Given this list of marker genes APEX2, MRPL37, LHX6, FAM227B, GAA, QSOX1, NUP54, EXOC2, AP1B1, DXO, TFAP4, OR7C1, MCAT, CIC, LRRC14, FBXO10, ARL4A, FBXO41, CKAP4, PRKCSH, LMNB2, LONP2, PPM1G, ARHGEF1, CD247, SAG, DHX30, ALKBH4, ACVR1B, PYM1, CCAR1, VPS33A, FAM204A (NCBI Gene Id 63877), WDR73, AP5B1, G3BP1, RNF220, RBM38, VPS4A, GLE1, FHOD3, KXD1, ANKH, ALDH1L2, TOMM20, PLCG1, CREBBP, ASB4 (ankyrin repeat and SOCS box containing 4), GPM6A, SNHG32, KCNK6, FSCN3, PNPLA1, BEND5, WDR82, STPG1, NKRF, RAB11B, REEP1, LYAR (NCBI Gene Id 55646), GNL3, FYN, GJB1, IP6K1, NRM, SCARB1, RAD1, RASL11B, RALGPS2, EXT1, MED24, EXOSC1, REXO4, RCC1L, HSD17B14, KCTD14, LSM2, ELF3, PCDHB7, WDR33, ARMCX2, RNF103 (NCBI Gene Id 7844), LIPT2, CNOT11, TNRC6B, RAB35, MAP3K14, PPP4R3B, PKD1, GABRG2, CHURC1, ZC3H8, S100A8, NAV3, PPIG, NXPE3, REV3L (REV3 like, DNA directed polymerase zeta catalytic subunit), PLD1, ERAL1, SLIT2, EIF3G, ZDHHC12, MAPK6, SNHG7, ENOPH1, SLC23A3, RBM34, PRR9, HIVEP3, RAB36, GPATCH4, RRAS2, SH2D2A, NMNAT3, EXOSC4, NOMO1, MTUS1, MCM2, RASSF2, B3GNT8, NFYA, POLR1C, PHLDA3, FPR3, SPAG16, FUCA1, BAX, ARL13A, BDH1, LRWD1, UBE2N, NIN, SET, RPL36, RAPGEF1, MED13L, BTC, LPXN, TTC13, DDRGK1, ZNF346, HADHA, CCDC86, DNAJB4, SEC14L5, DGCR6, BHLHE40, GSTM4, UGGT1, RAP2B, CYLC1, MYCBP (MYC binding protein), CDK13, TACC1, IFIT1B, SMARCC2, SELENOP, NUP155, VAMP2, ASCL1, ZC3H12D, CD6, SYNRG, USP39, ZFP64, PNMA8B (NCBI Gene Id 57469), FOXN3, SH3BP5, CHERP, SHMT2, FADS6, PMF1, TUFM, PIP5K1C, ENTPD6, PSMG2, GCSAM, HPCAL4, SACS, NUDCD2, DTWD1, MAP2K2, COX16, ANKRD10, PATJ, GPR174, GATD1, RNF44 (ring finger protein 44), PBX1, PIGY, ABHD12, IRF2, EIF3B, ZBTB8A, ITFG2, RFFL, MSN, COQ6, ATP11C, ANAPC15, here is a description of the gene set: Dendritic cells (DCs) process and present self and foreign antigens to induce tolerance or immunity. In vitro models suggest that induction of immunity is controlled by regulating the presentation of antigen, but little is known about how DCs control antigen presentation in vivo. To examine antigen processing and presentation in vivo we specifically targeted antigens to the two major subsets of DCs using chimeric monoclonal antibodies. Unlike CD8+ DCs that express the cell surface protein CD205, CD8- DCs, which are positive for the 33D1 antigen, are specialized for presentation on MHC class II. This difference in antigen processing is intrinsic to the DC subsets and associated with increased expression of proteins associated with MHC processing. species: Homo sapiens Genes down-regulated in splenic DEC205+ dendritic cells versus CD4 T cells. Human Gene Set: GSE6259_DEC205_POS_DC_VS_CD4_TCELL_DN from publication Dudziak D, Kamphorst AO, Heidkamp GF, Buchholz VR, Trumpfheller C, Yamazaki S, Cheong C, Liu K, Lee HW, Park CG, Steinman RM, Nussenzweig MC (PMID 17204652)